Given this list of marker genes CYP11B1, TP53 (NCBI Gene Id 7157), WWOX, NR0B1, AKT1, GATA4, MC2R, KEAP1, DICER1, MDM2, NNT, SOX9, CHEK2, TXNRD2, STK11 (NCBI Gene Id 6794), STAR, VAMP7, MRAP, WT1, FLI1, IGF2, SRY, NR5A1, KANSL1, MAP3K1, CDKN1B, DHX37, ZFPM2, STS, PRKAR1A, CDKN2A, PDE11A, CDC73, AR, EWSR1, here is a description of the gene set: species: Homo sapiens Neoplasm of the male external genitalia A tumor (abnormal growth of tissue) of the male external genitalia. Human Gene Set: HP_NEOPLASM_OF_THE_MALE_EXTERNAL_GENITALIA